The following is a description of a gene set: Mouse Gene Set: GOCC_MEDIATOR_COMPLEX A protein complex that interacts with the carboxy-terminal domain of the largest subunit of RNA polymerase II and plays an active role in transducing the signal from a transcription factor to the transcriptional machinery. The mediator complex is required for activation of transcription of most protein-coding genes, but can also act as a transcriptional corepressor. The Saccharomyces complex contains several identifiable subcomplexes: a head domain comprising Srb2, -4, and -5, Med6, -8, and -11, and Rox3 proteins; a middle domain comprising Med1, -4, and -7, Nut1 and -2, Cse2, Rgr1, Soh1, and Srb7 proteins; a tail consisting of Gal11p, Med2p, Pgd1p, and Sin4p; and a regulatory subcomplex comprising Ssn2, -3, and -8, and Srb8 proteins. Metazoan mediator complexes have similar modular structures and include homologs of yeast Srb and Med proteins. species: Mus musculus, and this is the list of marker genes: Uxt, Nfe2l2, Med22 (NCBI Gene Id 99421), Med28, Med20, Havcr2, Cdk8, Med16, Ccnc, Ppargc1b, Med26, Med7, Med10, Med14, Thrap3, Med18, Med23, Med13, Med12, Med25, Med9, Bclaf1, Bclaf3, Med21, Med4, Med1, Med13l (mediator complex subunit 13-like), Med29, Med12l, Med19, Med17, Med31, Med11, Med30, Med8, Med27, Med6, Med24